Given this list of marker genes Eno1, Bnip3, Pink1, Kdm6a, Zfas1, Trp53, Hyou1 (NCBI Gene Id 58204), Nol3, Eno1b, Pik3cb, Tmbim6, Map2k1, Atf2, here is a description of the gene set: Mouse Gene Set: GOBP_INTRINSIC_APOPTOTIC_SIGNALING_PATHWAY_IN_RESPONSE_TO_HYPOXIA species: Mus musculus The series of molecular signals in which an intracellular signal is conveyed to trigger the apoptotic death of a cell. The pathway is induced in response to hypoxia (lowered oxygen tension). Hypoxia, defined as a decline in O2 levels below normoxic levels of 20.8 - 20.95%, results in metabolic adaptation at both the cellular and organismal level. The pathway ends when the execution phase of apoptosis is triggered.